Given this list of marker genes DNAJC30, LRPPRC, SLX4, DNAI1 (dynein axonemal intermediate chain 1), CCNQ, INTU, LUZP1, PKD1L1, DNAH11, UBE2T, ERCC4, GNB2, RAI1, NXN, MMP2, VAC14, CFAP298, FANCA, BAZ1B, GATA4, RBPJ, CFAP221, TBX5, EOGT (EGF domain specific O-linked N-acetylglucosamine transferase), RNU4ATAC, ACVR2B, CIROP, GABRD, XRCC2, RREB1, SPEF2, ROBO1, PLD1, DNAAF5, GAS1, GJA1, MCTP2, SPAG1, LMNA, SMARCA4, RBM8A, QRICH1, CFC1, TMEM260, DISP1, RFC2, NODAL, DNAI2, FANCC, OTUD5 (OTU deubiquitinase 5), TUBG1, NEK10, TGIF1, LRRC56, VPS37D, FIG4, NIPBL, CACNA1C, RAD51C, DDX3X, CRIPTO, MAPKAPK5, PRKCZ, KDM6A, UFD1, ZIC3, MED13L, STRA6, TBX2, FANCI, SUFU, DGCR6, CXCR2, DNAAF2, BUD23, NOTCH1, RPL11, DDX11 (NCBI Gene Id 93260), EIF2AK3, SEMA3E, FBXL4, SPECC1L, NME8, RAD21, FANCM, SOX4, FOXJ1, DNAH9 (NCBI Gene Id 8709), PAH, PTCH1, HLA-B, GJA5, LIMK1, DNAH1 (NCBI Gene Id 25981), RFWD3, RSPH4A, CASZ1, SKI, PDPN, FOXF1, CCDC40, PLXND1, GJA8, DNAL1, PIGL, CHD7, MEGF8, TBC1D24, SALL1, GDF1, SIX3, RERE, DNAAF4, FKTN, CFAP300, SEC24C, DACT1, SHH, RAB23, ARID1B, PEX19, DNAAF1, FANCF, ESS2, KCNAB2, DRC1, MAD2L2, GATA5, CITED2, ARID2, NCF1, CCDC22, PUF60, TMEM270, GAS2L2, DDX59, BRAF, DGCR8, MCIDAS, ZEB2 (zinc finger E-box binding homeobox 2), RSPH1, TAB2, FOXC2, VPS35L, FANCG, GTF2I, SLC35A2, FOXH1, CFAP53, ODAD2, SALL4, SOX11, ZNF462, FKBP6, ODAD3, NOTCH2, TTC12, UBE2A, ARVCF, DOCK6, DAW1, GPC4, SMARCB1, SKIC3, SF3B4, OFD1, IPO8, BCOR, NIPA1, UBE4B, CHD4, TBX1, DNAAF11, SMARCC2, FANCB, P4HA2, MKKS, FGF8, WT1, ELN, NME5 (NCBI Gene Id 8382), PALB2, SF3B2, GLI2, BICRA, MMP14, GTF2IRD2 (GTF2I repeat domain containing 2), NKX2-6, SPEN, CDON, SRCAP, HLA-DRB1, TRAF7, PTPN22, BRIP1 (NCBI Gene Id 83991), RPL5, WASHC5, DLL1, RPGR, NR2F2, SMARCE1, TMEM94, ARHGAP31, HYDIN (HYDIN axonemal central pair apparatus protein), CDK8, ROR2, FANCL, RSPH9, ARID1A, COMT, ALX1, SH3PXD2B, MMP21, NKX2-5, CHRM3, GTF2IRD1, KDR, GP1BB, FLT4, HSPG2, PLCH1, BMP2, PHGDH (phosphoglycerate dehydrogenase), STX1A, GATA6, PIGN, JMJD1C, ZFPM2, DNAJB13, HIRA, ALX3, KMT2D, SMARCD1, ATP6V1B2, ZIC2, NADSYN1, SKIC2, PQBP1, CFAP74, EIF4H, SMAD2, GPC3, DLL4, HIBCH, METTL27, NIPA2, CXCR4 (NCBI Gene Id 93405), ODAD1, CCDC39, BRCA2, ZMPSTE24, DGCR2, MMP23B, SMG9, PRDM16, DNAAF3, FANCD2, CHUK, TBL2, DPYSL5, DNAH5, ODAD4, DNAAF6, EHMT1, MYRF, RRAS2, RAD51, DPF2, STAG2, COX7B, STK36, BRCA1, CCNO, GNPAT, ZMYND10, JAG1, FANCE, SLC37A4, CLIP2, RSPH3, ATP2B1, RBM10, FGFR1, here is a description of the gene set: A deviance in the normal connections between two cardiac segments. Human Gene Set: HP_ABNORMAL_CONNECTION_OF_THE_CARDIAC_SEGMENTS Abnormal connection of the cardiac segments studied in species Homo sapiens